The following is a description of a gene set: from publication Cao J, O'Day DR, Pliner HA, Kingsley PD, Deng M, Daza RM, Zager MA, Aldinger KA, Blecher-Gonen R, Zhang F, Spielmann M, Palis J, Doherty D, Steemers FJ, Glass IA, Trapnell C, Shendure J (PMID 33184181) The gene expression program underlying the specification of human cell types is of fundamental interest. The study authors generated human cell atlases of gene expression and chromatin accessibility in fetal tissues. For gene expression, the study authors applied three-level combinatorial indexing to >110 samples representing 15 organs, ultimately profiling ~4 million single cells. The study authors leveraged the literature and other atlases to identify and annotate hundreds of cell types and subtypes, both within and across tissues. Our analyses focused on organ-specific specializations of broadly distributed cell types (such as blood, endothelial, and epithelial), sites of fetal erythropoiesis (which notably included the adrenal gland), and integration with mouse developmental atlases (such as conserved specification of blood cells). These data represent a rich resource for the exploration of in vivo human gene expression in diverse tissues and cell types. species: Homo sapiens Human Gene Set: DESCARTES_FETAL_CEREBELLUM_VASCULAR_ENDOTHELIAL_CELLS Marker genes curated from the annotated cluster as represented in the Descartes Human Gene Expression During Development database., and this is the list of marker genes: LAYN, ANGPT2, EGFL7, LAMC3, ENPEP, CAVIN1, LINC00607, GPR4, AFAP1L1, FKBP9P1, FABP4, IFI27, CD320, LINC00877, SMTN (NCBI Gene Id 6525), APCDD1, FOXC2, ISG15, JCAD, XRCC6P5, SH3TC2-DT, MIR4435-2HG, CXXC1P1, PRSS12, SLC39A8, MSX1, GPR146, CETP, ERICH4, MYL12B, ZNF503-AS2, TEK, EMX2, SLC1A4, NIP7, UACA, C20orf202, SLC5A6, C1QTNF1, ADA, CCDC85B, PGF, SLFN5, CYSLTR2, SERPINH1, SLC14A1, ERAP2, RN7SL69P, SHC1, MOB2, GPD1L, COX7A1, FMO1, MFSD6L, TPT1P15, ABCB1, APOL3, PINK1, HEG1, TNFRSF10A-DT, APLN, NHERF2, TM4SF18-AS1, WWP1-AS1, TBX3, PELO-AS1, WFS1, LINC02237, OCLN, SLC46A3, XPNPEP2, RHOB, RAB13, KIF17, PEAR1, ITGA11, IL32, TBX18, FN1, MYZAP, EFNA1, C1orf54, COL18A1, P2RX5-TAX1BP3, LINC02172, HBG2, SLC39A10, PAMR1, CAMTA1-IT1, OLFML2A, FAM124B, GADD45A, CDC42EP1, DPEP1, TIE1 (NCBI Gene Id 7075), KANK3, UPB1, ERVMER34-1 (endogenous retrovirus group MER34 member 1, envelope), MAP3K6, NPIPB4 (nuclear pore complex interacting protein family member B4), CDH5, LAMC1, ICA1-AS1, S1PR3, ERVH48-1, HTR1F, CAV2, ITM2A, MAP4K2, CDH6, MIR126, CKMT2, TUBB1, ENSG00000235834, CDA, BSG, TWIST1, TBX2, CD248, MYO10, CLEC3B (NCBI Gene Id 7123), S100A10, ACVRL1, PLEKHF1, PTMAP5, TNFAIP8L1, TM4SF1, ENG, HES1, SERTAD1 (NCBI Gene Id 29950), PLOD1, HBZ, EVA1B, FOXL1, LINC02266, OR9Q1, SLC52A3, SLC7A1, TEAD4, GGT5, APLNR, LYPD3, KLF4, PRKCH, TAX1BP3, TNFRSF4, DIPK2B, TMEM88, ADORA2A-AS1, PELO, NPAS2, TDRG1, VSIG2, LINC01139, LMCD1, STOML3, HEYL, SH3TC2, NRARP, OLFML1, DLL4 (NCBI Gene Id 54567), CLEC2B, NOS3, SPARC, TBX2-AS1, LNCEGFL7OS, FOSL2 (NCBI Gene Id 79579), RAB11FIP5, ENSG00000272243, NPIPB12, DENND2C, BGN, MARVELD2, CDC42EP2, HELZ2, PPP1R14A, LINC02475, SHANK3, HSPG2, SLC7A11, ECM1, ADCY4, ASB9 (NCBI Gene Id 79067), ITGA1, MYO1C, PTPRB (protein tyrosine phosphatase receptor type B), PRSS23-AS1, LINC00702, MATN3, EPN3, ALS2CL, ESAM, GNG11, B3GNTL1P1, GPRC5C, FILIP1, DBH, IGF2, TGM2, FSTL1, GBP6, GATA2, UCP1, RGCC, EPAS1, GIMAP1, COBLL1, PLAC9, F2RL2, TCEAL8, RPS26P28, TAGLN, SYNM, PRELP, CLIC5, TENT5C, FENDRR, SYDE1, FOXD1-AS1, PLS3, TGFB1I1, PROCR, FOXD1, SEMA3G, TBX1, ENSG00000272789, TNFAIP1 (NCBI Gene Id 7126), TFRC, MMRN2, RBPMS, SMG1P2, RLN2, NODAL (nodal growth differentiation factor), DEPP1, CD109, IGFBP4, LINC01644, CARMN, DSP, TDRD1, REM1 (NCBI Gene Id 28954), MCAM, GIMAP6, ZNF503, ETS1, TAGLN2, CRIP2, ADGRF5, TBXA2R, BCL6B, XIRP2, ST6GALNAC1, SLC6A12, CGNL1, LINC00678, SLC16A12, PCDH12 (NCBI Gene Id 51294), LINC02185, IFI6, ARHGAP18, CA2, FOXF1, CNN2, GRAP, CLDN5, SIGIRR, PRR29, HIGD1B, VWA2, HEMGN (NCBI Gene Id 55363), TMEM204, ERG, TNN, SHE, LINC02765, HSPA12B, EDN1, JPH2, DPPA4, GIPC3, LINC02507, ANXA1, ZAP70, CFH, RPL17P21, C16orf89, HYAL2, DOK4, ABCG2, LINC01612, MYCT1, GJA4, LSR, ANAPC1P4, EDNRA, IQSEC3-AS1, CCDC86-AS1, NOSTRIN, FKBP9, CRYBB3, CLEC11A, SLC7A5, CARD10, VANGL1, CCDC141, LRRC55, DACT2, FAM110D, KIF26A, GBP1, MFSD2A, PALMD, ISM1, ACTA2, ENSG00000272473, S1PR5, CASTOR1, FKBP1A (FKBP prolyl isomerase 1A), KL, DCBLD1, AVPR1A, IFITM2, RUNX3, SLC26A6, IFITM1, ZNF366, FOXQ1, WWTR1, VWA1, GASAL1, NOTCH3, CDKN2B, PTH1R, SMG1P4, IAPP, USHBP1, ITIH5, CAVIN3, MIR3667HG, CALD1, LINC02147 (NCBI Gene Id 124901051), PCDH18, LINC02104, CCN1, CAVIN2, LINC00840, CASP4LP, FOXF2, FLVCR2, LCIIAR, EPHA2, P2RY14, OSMR, FHL3, SRARP, VWF, LTF, EMX2OS, ECE1, KCNE4, C4orf3, ADORA2A, SLC19A4P, ALDH3A1, LINC02982, MUSTN1, ADGRL4, SLC38A11, LINC02043, ARHGAP29, CFP, COL3A1, SLC38A5, TCIM, BTNL9, TM4SF18, SLCO1A2, MYO1B (NCBI Gene Id 92451), MIXL1, DEGS2, SOX17, COL4A2, F2RL3, SLC12A7, BHLHE40, SLC3A2, PLXDC1, LRRC32, ZNF792, MYL9, SLC9A1, MT1E, SLC7A5P2, CD79B, FLT4, SNAI2, CCN2, MYCBPAP, HBA2, C1orf115, MEDAG, HSPD1P6, OR51E1, ZBTB42, PROSER2, SULT1B1, L1TD1, CTSK, RASIP1, ROBO4, RGS3, IGFBP7, TNXB, KANK4, IFIT3, CD19, HOPX, PHLDB2, GPER1, MT1X, ACTN4, SLCO1B1, STRA6, GATA2-AS1, CD300LG, CLEC1A, PHOSPHO1, ENSG00000255462, SLC38A2, IQGAP2, PDGFRB, VAMP3, LINC00636, CRIP1, CCDC102A, UNC5B, NIBAN2, APOL2, CALHM5, LINC01391 (long intergenic non-protein coding RNA 1391), G6PC2, KCNJ2, RRAS, ANGPTL4, HBA1, LAMB2, FGR, LEF1-AS1 (NCBI Gene Id 641518), TIMP1, CD93, CRYBB2, SLC26A2, FOXC1, OAF, MYL12A, STARD8, ENSG00000251661, SP6, THSD1, PODXL, S100P, SLC16A1, SLC38A3, CD34, ACE, WWTR1-AS1, SLC38A2-AS1, CASP12, POLR2L, ENSG00000223786, VIP, SLFN12L, NKX6-1, NAMPTP1, OAS2, SPAAR, CRIPTO, IFITM3, TSC22D3, KLF2, S100A16, IFIT1, QPCT, FZD4, PCOLCE, LEF1, PTGIR, RHOC, LMO2, HRCT1, CD82, GBP3, PRND, SMAGP, LMOD3, MYLK2, BTNL8, GBP4, VAMP5, FOXF2-DT, KLK1 (kallikrein 1), DAAM2, FAM43A, PCAT19, JAML, LATS2, SLC22A10, RPLP0P2 (NCBI Gene Id 113157), RASL12, HID1-AS1, COL6A2, PPIC, ARHGEF15, RGS5, PTP4A3, CSRP1, TMEM125, PRKCH-AS1, PTGDR2, THBD, CSAG1, CARD8-AS1, AIRE, LINC01099, ITPR3, GIMAP7, HIC1, SMG1P3 (SMG1 pseudogene 3), RNU6-1045P, PRRG2, ADGRA2, STC2, LXN, ATP10A, RFLNB, ID3, ITGA2-AS1, EFEMP2, EXOC3L1 (NCBI Gene Id 283849), HBB, LDLRAD2, FLT1, RP1, ENSG00000257002, MELTF, KIAA0040, TRGC1, SOX18, LINC02148, CCM2L, AHNAK, TMEM92, CAV1 (NCBI Gene Id 857), ADM, ATP8B1, ANPEP, SERPINE1, HTRA3, HBG1, ARAP3 (ArfGAP with RhoGAP domain, ankyrin repeat and PH domain 3), SMIM10, CDC42EP5, TCF15, C8orf58, TTN, ST6GALNAC4, GCOM1, TRPC6, PRX, CD27, EMCN, TINAGL1, ID1, OCEL1, SLCO2A1, SLC2A1, SHROOM1, TAMALIN, SRPX2, EDN3, RAMP2, LHX6, RHOD, LINC03033, TMEM37, BCAM, NDUFA4L2, NOS2, GLRX5, EHD2, KCNJ8 (NCBI Gene Id 3764), ECSCR, LINC02126, SULT1E1, C2CD4B, ABHD17A, EIF5AL1, TMEM45B, ENSG00000245008, COL4A1, SOX7, PDLIM1, CCDC3, PDGFB, SPINK8, SELE, MECOM, CAPNS1, CIMAP1D, SAMM50, NACA2, ABCC9, DLC1, WWTR1-IT1, MMP25, KLF10, NOTCH4 (notch receptor 4), DSP-AS1, NKD2, AGRN, PIM3, FGD5, NID1, LINC02751, HLX, F2RL1, LINC02836, ANO2, MOCS1, RASD2 (NCBI Gene Id 57347), INF2, ANXA2R, IQGAP1, ALX4, IL1R1, RPS14P4, SH2D3C, KDR, FOXS1, TNKS1BP1, SLC6A13, TCF7 (NCBI Gene Id 6932), DUSP6, AURKAP2, KLF13, FOXL2, RPS14P5, ICAM2, MECOM-AS1